Given this list of marker genes TRAT1, ADA, TREM2, APP, ZAP70, NMUR1, PPP3R2, EDN1, RAMP3, NEUROD2, CDH13, SLC8A2, IGF1, CCL3, JPT2, CALCR, CLEC7A, PCP4, SLC9A1, PDGFRB, PPP3CB, CALM3, AKAP6, ITPR1, HINT1, RGN, NEGR1, HOMER2, MYOZ2, PTPRC, PDK2, PPP3R1, INPP5A, P2RX5, GBP1, EFHB, CD3E, SLC24A4, EDN2, SYK, MYOZ1, RCAN1, PRKACA, FKBP1B, TMBIM4, MAPK7, C10orf71, TMEM100, MAPT, TBC1D10C, PRNP, P2RX2, PPP3CC, GSK3B, LMCD1, CHP2, GPR62, SPPL3 (NCBI Gene Id 25881), P2RX4, P2RX3, AKAP5, PTPRJ (NCBI Gene Id 5795), TNF, IAPP, CHP1, RIT2 (Ras like without CAAX 2), CIB1, SELENOK, FHL2, CALM2, PLCG2, LRRK2, CAMTA1, ATP2B4, LACRT, ERBB3, CMKLR1, MTOR, PPP3CA, HTT, CD4, CA8, BST1, PLEK, HOMER3, NFAT5, PDGFRA, CHERP, SLA2, PTBP1, CCL4, GRM5, CALM1, MYH7B, DYRK2, ACTN3, HTR2C, NMUR2, CD22, here is a description of the gene set: species: Homo sapiens Any process that modulates the frequency, rate or extent of calcium-mediated signaling, the process in which a cell uses calcium ions to convert an extracellular signal into a response. Human Gene Set: GOBP_REGULATION_OF_CALCIUM_MEDIATED_SIGNALING